Given this list of marker genes CRIP1, GCHFR, ATP6V0E2, B3GNT8, ATG16L2, NUDT8, CCDC88B, ARHGAP40, RAB5IF, RDH14, PRR7, VSIG2, ZNF524, LMTK3 (lemur tyrosine kinase 3), MUC20, TBX1, JUND, C10orf95, CYSRT1, SLC25A29, AATBC, OSR1, ANKRD9, ANPEP, CCDC34, PCLAF, C15orf61, PAQR8, DHRS9, CDC45, GRHL3 (NCBI Gene Id 57822), SNCG, RPL39, SMIM5, AIF1L, TJP3, ACBD4, CASTOR1, TMPRSS2, CCDC74A, FAM111B, NOXA1, GABRP, ANXA9, PADI1, PDF, UPK2, RBP1, BSPRY, CAPS, RECQL4, TEDC2, LGALS7B, TM7SF2, MND1, YPEL3, E2F1, EMP2, PPP1R14A, RHPN1, TMEM160, ADIRF, CTU1, ECM1, COMTD1, UBE2S, ELF3, ANKRD23, UPK3B (NCBI Gene Id 80761), NICOL1, RBBP8NL, CFAP184, CALB1, NUDT3, TGFBR3L, TPGS1, LIMD2, TMEM125, HYAL1, RCOR2, IDI2-AS1, here is a description of the gene set: Human Gene Set: BLANCO_MELO_BRONCHIAL_EPITHELIAL_CELLS_INFLUENZA_A_INFECTION_DN Analysis of the transcriptional response to SARS-CoV-2 compared with other respiratory viruses, including MERS-CoV, SARS-CoV-1 (SARS), human parainfluenza virus 3 (HPIV3), respiratory syncytial virus (RSV), and IAV. species: Homo sapiens Genes down-regulated oninfection of normal human bronchial epithelial cells by Influenza A (MOI: 3, 12hpi) from publication Blanco-Melo D, Nilsson-Payant BE, Liu WC, Uhl S, Hoagland D, Møller R, Jordan TX, Oishi K, Panis M, Sachs D, Wang TT, Schwartz RE, Lim JK, Albrecht RA, tenOever BR (PMID 32416070)